The following is a description of a gene set: The hardening, enlarging and rising of the penis which often occurs in the sexually aroused male and enables sexual intercourse. Achieved by increased inflow of blood into the vessels of erectile tissue, and decreased outflow. studied in species Homo sapiens Human Gene Set: GOBP_PENILE_ERECTION, and this is the list of marker genes: ADA, OXT (NCBI Gene Id 5020), P2RY1, EDNRB (endothelin receptor type B), ACVR2A